The following is a description of a gene set: Genes up-regulated in comparison of peripheral blood mononuclear cells (PBMC) from TIV influenza vaccinee pre-vaccination versus that after the vaccination Human Gene Set: GSE29614_CTRL_VS_TIV_FLU_VACCINE_PBMC_2007_UP from publication Nakaya HI, Wrammert J, Lee EK, Racioppi L, Marie-Kunze S, Haining WN, Means AR, Kasturi SP, Khan N, Li GM, McCausland M, Kanchan V, Kokko KE, Li S, Elbein R, Mehta AK, Aderem A, Subbarao K, Ahmed R, Pulendran B (PMID 21743478) Systems vaccinology has emerged as an interdisciplinary field that combines systems wide measurements and network and predictive modeling applied to vaccinology. Here we used the systems vaccinology approach to study the molecular mechanisms underlying the innate responses to the trivalent inactivated influenza (TIV) and live attenuated influenza (LAIV) vaccination in humans, and to identify early gene signatures that predict the magnitude of the antibody responses to influenza vaccination. species: Homo sapiens, and this is the list of marker genes: PCDHA9, NBPF5P, MYH7 (NCBI Gene Id 8090), L3MBTL1, ANGPTL1, LHFPL3, LINC02877, COL4A5, KCNJ8, TSTD2, LINC02483, MYOT, SLC18A3, HYAL6P, WASIR2, DCST2, BMP2, LCN6, DCBLD2, CRYGN, MATN4, CST9L, FRMD6, AZGP1P1, HSD11B1L, ERLEC1P1, GALNT5 (polypeptide N-acetylgalactosaminyltransferase 5), ADAMTS9-AS2, LENEP, MALRD1, PCOLCE2, ZSCAN1, C15orf32, PRKACG, PPFIA1, ELOA2, PDLIM7, OR7E19P, CDC40, C2CD4C, KCNK4, KLHL41, SLC24A5, ERBB4, SERPINB11, FAM185A, DUOX1, POLE4, COL15A1, INSM1, RAD51B, NTN1, LINC01949, KRTAP19-3, TGIF1, CTXN3, UBE2D3, EFNA3, PNLIPRP2, STRN3 (NCBI Gene Id 29971), SMCO1, CYP11B1, TRIM65, PLIN4, CCL2, CCNK, FLG2, AMELX, MIRLET7BHG, MIGA1, ADAM30, HMCN1, GJA8, KCNK9, SLC10A2, SALL3, NEU4, SMIM32, DDIT4, NANOS3, SEPTIN4, PANX2, GRM4, MESP1, ENSG00000235138, CTNNA2, OR8B8, LHB, ATP6V1G3 (NCBI Gene Id 127124), ABHD12B, SNX7, ABHD8, OR8G1, EDN2, GRIK2, NCOA1, IL24, ZBTB49, CDH12, OTOGL, PHACTR2-AS1, MAPT, DAB1, ADAMTS8, TLL1, OR8G2P (NCBI Gene Id 282783), LINC00216 (long intergenic non-protein coding RNA 216), HAAO, OR1A2, ECSIT, LDHAL6A, TPTE2P6, RIPPLY3, RPL23AP32, ZDHHC2, BPIFB1, SLC9A3, IL17RE, DRD5, FZD10-AS1, PRX, CAPN6, FUT1, NMD3, PER3P1, GJD4 (NCBI Gene Id 219770), ALDH3A1, TEX14, MCMDC2, AIRE, LINC01968, FMO6P, FGFR3, FSHR, IL22RA2, TRPA1, ACSM5, MLNR, IGSF3, CYP4A22, UBXN10, STK4, RASA1, SPATA31G1, KCNJ4, ZNF157, CPQ, SLC38A3, SNORC, TRPC6, ACVRL1, KRBOX1, ADARB2, SYDE1, SPRR2B, EPHX3, USP25, SMAP1, TRIM16L, SPMIP6, DPEP1, ULBP1, PARVA, NXNL1, NIM1K, KLHL34, CASC2, OR52D1, SMTN, GPX5, CFAP99, LINC00955, PEBP4, LINC00276, C9orf163, UQCRFS1, LINC02912, SOX4, PITX2, ASIC3, SPATA45, GAD1, C7orf33 (chromosome 7 open reading frame 33), TAFA5, CREB3L3 (NCBI Gene Id 84699), ADAMTSL5, DNAJB5, HOXA-AS2, LINC01095 (long intergenic non-protein coding RNA 1095), PDZRN4